The following is a description of a gene set: species: Homo sapiens Increased intensity of the a reflex in the arm. Upper limb hyperreflexia Human Gene Set: HP_UPPER_LIMB_HYPERREFLEXIA, and this is the list of marker genes: SDHD, CYP2U1, RTN2, CAPN1, SPG7, KIF5A, KPNA3, VPS37A, SPG11, ANO10 (NCBI Gene Id 55129), SDHB, ALDH18A1, WASHC5, ATP13A2, SPAST, UBAP1, COQ4, SDHAF1, ERLIN2, TNR, REEP1 (receptor accessory protein 1), SDHA, TMEM63C, SPTLC2, HSPD1, FTL, ABCC9